The following is a description of a gene set: studied in species Mus musculus This event has been computationally inferred from an event that has been demonstrated in another species.<p>The inference is based on the homology mapping from PANTHER. Briefly, reactions for which all involved PhysicalEntities (in input, output and catalyst) have a mapped orthologue/paralogue (for complexes at least 75% of components must have a mapping) are inferred to the other species. Reactome Pathway: Interleukin-35 Signalling electronically inferred by orthology from the curated human pathway part of: Interleukin-12 family signaling, and this is the list of marker genes: Stat4, Il12a, Il27ra, Tyk2 (NCBI Gene Id 54721), Ebi3